Given this list of marker genes PIERCE1, KASH5, SMAGP, CRYAB (crystallin alpha B), STEAP3, KCNE4, STEAP2, ZEB2, OPN3, AKAP13, MAP7D3, SH3GL3, IGF2BP1, NANOS1, DUSP6, MLLT3, XG, EZH2, PLPP6, GPD2, FAT3, CD99P1, CMPK2, FYN, G0S2, SH2B3, AKAP7, IFITM1, TRIB1, MDFI, NPR3, NID1, GSTM4, RCOR1, CMTM3, ARHGEF6, GATA2, BCL2L1, IL17D, ISM2, AKR1B10, JCAD, RARRES2, NPTXR, SLC12A6, WDFY2, KDSR, NMI, UBE2L6, PTTG1IP, CUL4B, MGARP, EPHA2, RALGPS2, TBC1D9, JAK1, HIP1R, TAGLN3, FGFR1, PHKA1, PHOSPHO1, CASP3, GRK5, SPTBN1, KSR1, YPEL5, MGAT5, PODXL, PGM2L1, P2RX7, SSBP3, NFATC4, RGS10, HHIP, ICAM1, IER5L, DGKD, RCN3, GALNT3, HOXA13, CHMP1B, FZD4 (frizzled class receptor 4), CDH11, ADCY9, SLC17A7, ID2, CD99, ITGB2, KCNE3, ROCK2, SPTLC2, ABHD6, LINC02762, EPHB2, CD58, PLCD3, ZSWIM6, CLEC11A, SDCBP2, EFHD2, KRT19, OAF, ITGAM, HIPK1, SAP30, ELN, RUBCNL, SLC1A4, ADARB1, TMEM44, TOX2, TGM2, HOXD10, ERCC6, DAPK1, PAQR5, FOXL2, HAPLN1, SIGLEC15, RAB11FIP1, KIAA1217 (NCBI Gene Id 56243), SYNE2, IGFBP2, TCF12, GCH1, GLCE, RAPH1, IL1RAP, CEACAM1 (NCBI Gene Id 634), SOX4, IMPA2, PTPN13, KCNN1, STAR, SULT1A2, FGF18, GP1BB, PREX1 (NCBI Gene Id 57580), NKX1-2, NT5DC1, PTPN22, LRIG3, CLDN1, HS3ST3B1, HMGB3P1, FAM43A, SIX1, GPR137B, JAG1, ARHGDIB, ZNF703, HLA-E, SH3KBP1, P2RX4, NTNG1, HMGB3, KALRN, ERFE, MALL, PGF, MRPS22, LGALS8, FZD7, MAFB, PRND, CABLES1, TBL1XR1, BHLHE41, FKBP1A, SORD, ASAP1, ATP1A1, BAHCC1, PRSS35, ADCY4, SNX18, HSPB2, CDC42EP5, NEURL1B, KRT18, SSPN, WWC3, AP4B1, TNNT1, DPYSL2, TSPAN13, FUCA1, ZC3H12C, SLC35F2, STEAP1, ETV6, CDK1, RPS6KA5, EMP2, KCTD12, ADRA1D, TMEM164, APOL6, CD79A, C1QL1, SLC43A1, NGFR, ARRDC2, ECSCR, LRCH1, CHST1, HMCN1, ENSG00000272970, FBLN5 (fibulin 5), TRIM62, ANKH, COL21A1, DNAJC12, GLG1, ZDHHC21, CDK14, DCAF7, TSC22D3, ST3GAL5, RAMP2, FCHSD2, SLC26A2, KLF3 (NCBI Gene Id 51274), TMEFF2, NKX2-2, MAPK13, FZD8, DPF3, EVA1B, TM4SF1, EPB41, GSTM1, SLC7A11, KMO, LBH, ICAM2, RNF19B, MEDAG, FLI1, HSD17B2, DPP4, ITGB2-AS1, TEAD2, TRIM69, SEMA3F, KIT, EFNB1, EVA1C, USP6NL, PPARA, CPPED1, TRNP1, CSPG5, EPHB3, SIRPA (signal regulatory protein alpha), FAS, PADI2, RSPH3, MMP3, FNBP1, EPOR, CES1, KLF2, FARP1, SPATA13, here is a description of the gene set: Ewing's family tumor (EFT) is a rare pediatric tumor of unclear origin that occurs in bone and soft tissue. Specific chromosomal translocations found in EFT cause EWS to fuse to a subset of ets transcription factor genes (ETS), generating chimeric EWS/ETS proteins. These proteins are believed to play a crucial role in the onset and progression of EFT. However, the mechanisms responsible for the EWS/ETS-mediated onset remain unclear. Here we report the establishment of a tetracycline-controlled EWS/ETS-inducible system in human bone marrow-derived mesenchymal progenitor cells (MPCs). Ectopic expression of both EWS/FLI1 and EWS/ERG proteins resulted in a dramatic change of morphology, i.e., from a mesenchymal spindle shape to a small round-to-polygonal cell, one of the characteristics of EFT. EWS/ETS also induced immunophenotypic changes in MPCs, including the disappearance of the mesenchyme-positive markers CD10 and CD13 and the up-regulation of the EFT-positive markers CD54, CD99, CD117, and CD271. Furthermore, a prominent shift from the gene expression profile of MPCs to that of EFT was observed in the presence of EWS/ETS. Together with the observation that EWS/ETS enhances the ability of cells to invade Matrigel, these results suggest that EWS/ETS proteins contribute to alterations of cellular features and confer an EFT-like phenotype to human MPCs. Genes commonly up-regulated in UET-13 cells (mesenchymal progenitor) by expression of EWSR1 fusions with ETS transcription factors FLI1 and ERG. studied in species Homo sapiens Human Gene Set: MIYAGAWA_TARGETS_OF_EWSR1_ETS_FUSIONS_UP from publication Miyagawa Y, Okita H, Nakaijima H, Horiuchi Y, Sato B, Taguchi T, Toyoda M, Katagiri YU, Fujimoto J, Hata J, Umezawa A, Kiyokawa N (PMID 18212050)